The following is a description of a gene set: The biosynthetic process resulting in the formation of DNA. Human Gene Set: GOBP_DNA_BIOSYNTHETIC_PROCESS species: Homo sapiens, and this is the list of marker genes: TOM1L1, TENT4B, CDKN1A, RRM1, LOX, EXOSC10, USP1, PCNA, FBXO4, SYCP1, POLK, CCT2, POLD3, NOX4, HROB, RFC1, TERF2, POLL, NIBAN2, POLD4, CHRAC1, HNRNPC, TYMS, ZBTB1, HNRNPU, CCN2, HMBOX1, NHP2, CTNNB1, NAF1, TP53, WRAP53, TERF2IP (TERF2 interacting protein), POLDIP2, ADIPOQ, JADE1, TREX1, RFC3, ATR, XRCC5, POLD2, SMG6 (NCBI Gene Id 80091), FGFR4, LIG3, POLE, USP10, CCT3, CCT5, DTL, REV1, DNTT, TEN1, ACD, SMG5, MAD2L2, POLQ, PDGFRB, TEP1, TERC, PCLAF, POLE3, KAT7, CDKN2D, CCT6A (NCBI Gene Id 908), POLE4, TCP1, VCP, SIRT1, POLA1 (DNA polymerase alpha 1, catalytic subunit), CCT7, ATM, LIG1, TINF2, HSP90AA1, TNKS, HTR2A, CENPF, SPHK1, TNKS2, FAAP20, TFDP1, RFC4, POT1, POLM, REV3L, RFC2, KCNK2, PARN, VEGFA, STN1, PRIMPOL, TERT, HSP90AB1, FGF2, HGF, CCNA2, NOP10, PARP10, CCT4, ING4, PIF1, DUSP1, JADE3, PDGFA, NPPC, POLG, RAD50, RFC5, TEX12 (testis expressed 12), POLN (NCBI Gene Id 353497), POLG2, CHTF8, POLD1, SPRTN, TK2, POLH, TNF, SH2B1, DACH1, ING5, DCP2, PHB1, DNAJC2, SPATA22, LIN9, LIG4, MRE11, USP43, RPA1, SMOC2, PARP3, TNKS1BP1, PDGFB, POLE2, WRN (WRN RecQ like helicase), POLB, PTGES3, JADE2, SMPD3, XRN1, GAR1, ANKRD1, POLI, RGCC, TK1, TERF1, RRM2B, CCT8, WRNIP1 (WRN helicase interacting protein 1), DSCC1, RCHY1, HNRNPA1, MEAF6, DKC1 (NCBI Gene Id 1736), NAT10, CHTF18, HNRNPD, PRKD2, NYNRIN, CTC1, PML, PINX1, GNL3L